The following is a description of a gene set: Normochromic anemia studied in species Homo sapiens Human Gene Set: HP_NORMOCHROMIC_ANEMIA, and this is the list of marker genes: SF3B1, RPS7 (ribosomal protein S7), RPS19, RPL35A, SRSF2 (NCBI Gene Id 6427), RPL8, ABCD4, LCAT, TET2, HEATR3, GATA1, RPS24, SCARB2, RPS15A, RPS17, RPS29, ADA2, HK1, RPL18, RPL9, RPL11, TPI1, ALDOA, RPL15, RPL26, RPS10, UQCRFS1, TREX1, KIT, RPL5 (NCBI Gene Id 90045), RPS27, TSR2, RPL31, RPL27, RPS20, ASXL1, RPS26, RPS28, RPL35